Given this list of marker genes HSP90B1, IGHG3, TNFRSF17, IGLV2-14, JCHAIN, IGHG1, FCRL5 (NCBI Gene Id 83416), TNFRSF13B, IGHD, IGLL1, PDIA6, TXNDC5, IGHE, here is a description of the gene set: Genes up-regulated in peripheral blood mononuclear cell 3d vs 0d in adults (18-45) after exposure to Menactra, time point 7D studied in species Homo sapiens from publication Li S, Rouphael N, Duraisingham S, Romero-Steiner S, Presnell S, Davis C, Schmidt DS, Johnson SE, Milton A, Rajam G, Kasturi S, Carlone GM, Quinn C, Chaussabel D, Palucka AK, Mulligan MJ, Ahmed R, Stephens DS, Nakaya HI, Pulendran B (PMID 24336226) Human Gene Set: LI_PBMC_MENACTRA_AGE_18_45YO_7DY_UP Many vaccines induce protective immunity via antibodies. Systems biology approaches have been used to determine signatures that can be used to predict vaccine-induced immunity in humans, but whether there is a 'universal signature' that can be used to predict antibody responses to any vaccine is unknown. Here we did systems analyses of immune responses to the polysaccharide and conjugate vaccines against meningococcus in healthy adults, in the broader context of published studies of vaccines against yellow fever virus and influenza virus. To achieve this, we did a large-scale network integration of publicly available human blood transcriptomes and systems-scale databases in specific biological contexts and deduced a set of transcription modules in blood. Those modules revealed distinct transcriptional signatures of antibody responses to different classes of vaccines, which provided key insights into primary viral, protein recall and anti-polysaccharide responses. Our results elucidate the early transcriptional programs that orchestrate vaccine immunity in humans and demonstrate the power of integrative network modeling.